Given this list of marker genes VKORC1L1, BMPR2, RACGAP1, HIPK4, CXADR, ROCK1, ATXN7, GPR37, ADAM19, ZBTB20, AMMECR1, APPL1, RBM24, CMTM8 (CKLF like MARVEL transmembrane domain containing 8), TMT1A, PTH, TUT4, OTUD4, C8orf88, ALOX5, ARL5B, QKI (NCBI Gene Id 9444), SLAIN2, MYCT1, OSBPL9, PDE9A, CFAP52, PTPRM, MYO6, RBM47, WASHC4, FREM1, STARD4 (NCBI Gene Id 154899), UGT1A4, ITPRIP, SLC1A2, CSRNP3, AFTPH, ABAT, ENTPD7, DSC2 (NCBI Gene Id 1824), CAMK2B, EFHD2, CNIH1, TBC1D30, PODN, GABRA4, LRAT, ERCC6L, ZC3H11A, PRKAA2, GRIA2, STAU2, PHC3, TBC1D24, KCNMB2, PLXDC2, ZNF254, UGT1A10, TRMT10A, HIF1A, ERBIN, BRAF, ADAMTS5, ACTL6A (actin like 6A), LUC7L2, RWDD2A, TRIO, ABHD17C, FAM8A1, PTEN (phosphatase and tensin homolog), LPP, RABGEF1 (RAB guanine nucleotide exchange factor 1), PKDREJ, SYT15, CDK5R1, MORC4, ACSL1, RIMS2, CD274, STXBP5, CDC40, UGT1A8, IL2, ZNF366, LACC1, DRAM1, TINAGL1, ZNRF2, ZNF354C, CYP1A2, ORC2, TMEM14A, NEK7, DPP9, KLHL28, SFRP2, FCHSD2, ZNF333, MYT1, UGT1A6 (UDP glucuronosyltransferase family 1 member A6), ADAM18, SLC35F5, PALS1, THOC7, CAMK4, CBX5, WDR20, MTFR2, ID2, ACYP2, MSMO1, PTAR1, RNF217, ARL13B, RHAG, IDI1, FPR3, NHLH2, RAB1A, SAMD12, RBM26, SRPK1, MOCS1, USP45, CNTN3, CDK6 (NCBI Gene Id 1021), PEX3, ANO6, METAP2, ZFAND5, RBM28, ZBTB1, NCOA1, GLRX5, POU4F2, RAB27B (RAB27B, member RAS oncogene family), SMG7, REPS2, ARMT1, TMEM233, AHR, AGL, UGT1A3, BICD2 (BICD cargo adaptor 2), FUT9, PTPRO, AFAP1L2, KIF13A, PCGF5, SAMTOR, FBXO33, FAM107B, PPM1B, MOB1A, CD55, IFNA21, PPP1R2, CSGALNACT2, SGO1, SLC36A4, PIK3CA, SCAI, LIN7C, ZNF43, MKLN1, OTUD6B, SGK3, NR1D2, OPN5, AKIRIN1, ARIH1, NAA25, DLG5, MFSD8, SPAST, NEXMIF, ZFAND3, CLK4, PAPSS1 (3'-phosphoadenosine 5'-phosphosulfate synthase 1), SAMD9, GAPVD1, KLHDC1, HOOK3, PCMTD1, PDE5A, RHOB, SSPN, CCNG1, HIVEP2, RELA, MYLK, AHCYL2, CAST, A1CF, CCDC182, ZNF117, ACSL4, CACNA1C, COG6, RPAP3, MYSM1, PAK2, CTSO, CCP110, SPO11, COPG2, CEP135, LRRN1, FAM120A, PLS3, GBP2 (guanylate binding protein 2, NCBI Gene Id 2634), CDC42EP3, MAP3K2, CHIC1, SIPA1L3, CLEC2D, DOCK9 (dedicator of cytokinesis 9), NOX1, FAR1, POFUT2, RASA3, MAP3K1, FZD3, NCSTN, VPS4B, ANK3, KIAA0408, NIPAL1, PRC1, RANBP3L, PGGT1B, WARS2 (tryptophanyl tRNA synthetase 2, mitochondrial), RLN2, APBB2, BBX, SH3TC2, ARPP19, LIN9, RIF1, UGT1A9, HNRNPF, PTGR3, SLFN12, CNTNAP2, UGT1A1, XIAP, DCUN1D4, BAG3, PPP2R2A, PDE3B, IFNA8, EIF1AX, HACD3, RICTOR, TRPC5OS, ZDHHC21, WAPL, RNF180, CEPT1, ZFP36L1, SYAP1, SIDT1 (NCBI Gene Id 54847), MCTS1, NUFIP2, ZNF131, RBM3, CFHR5, PALS2, HECTD2, MEAF6, DNAJC3, SUCLA2, F2RL2, TRIM33, TOP2B, RNGTT, GPR85, DLG1, SHROOM3, HNRNPR, UGT1A7, GRIK1, AP4E1, ERMN, BRIP1 (BRCA1 interacting helicase 1), ASCC3, PACRGL (parkin coregulated like), PTPN2, IFT70A, LINGO2, RPS6KA3, PHF21B, FGF2, KRT71, ZNF652, CRKL, USH2A, VLDLR, SPRYD7, SPOCK1, PRDM5, TSPAN12, STK39, NFAT5, ZNF486, QRFPR, MTCL3, ROCK2, UGT1A5, SLC4A7, C11orf58, EPRS1, SLC5A8, LRRTM3, MICU3, TP53I11, ZBTB41, NECTIN3, RPS6KA6, TRAPPC3, ABCG2, HYCC2, TMEM183A, RALGAPA1, CAMSAP2, ADRA1A, ZNF699, PDPK1 (NCBI Gene Id 5170), EPB41L5, FOXJ2 (NCBI Gene Id 55810), FMC1-LUC7L2, AAK1, IGSF11, TUBGCP3 (tubulin gamma complex component 3), PPM1F, IFNW1, KLHL31, ULK2, KLF9, ALG10B, CSN2, PRKG1, here is a description of the gene set: studied in species Homo sapiens Human Gene Set: MIR6507_5P from publication Chen Y, Wang X (PMID 31504780) Genes predicted to be targets of miRBase v22 microRNA hsa-miR-6507-5p in miRDB v6.0 with MirTarget v4 prediction scores > 80 (high confidence targets).